The following is a description of a gene set: from publication Hu T, Gibson DP, Carr GJ, Torontali SM, Tiesman JP, Chaney JG, Aardema MJ (PMID 15120960) studied in species Mus musculus Genes most consistently regulated at 4 h by all six genotoxins tested: cisplatin, methyl methanesulfonate, mitomycin C, taxol, hydroxyurea and etoposide. Human Gene Set: HU_GENOTOXIC_DAMAGE_4HR During the safety evaluation process of new drugs and chemicals, a battery of genotoxicity tests is conducted starting with in vitro genotoxicity assays. Obtaining positive results in in vitro genotoxicity tests is not uncommon. Follow-up studies to determine the biological relevance of positive genotoxicity results are costly, time consuming, and utilize animals. More efficient methods, especially for identifying a putative mode of action like an indirect mechanism of genotoxicity (where DNA molecules are not the initial primary targets), would greatly improve the risk assessment for genotoxins. To this end, we are participating in an International Life Sciences Institute (ILSI) project involving studies of gene expression changes caused by model genotoxins. The purpose of the work is to evaluate gene expression tools in general, and specifically for discriminating genotoxins that are direct-acting from indirect-acting. Our lab has evaluated gene expression changes as well as micronuclei (MN) in L5178Y TK(+/-) mouse lymphoma cells treated with six compounds. Direct-acting genotoxins (where DNA is the initial primary target) that were evaluated included the DNA crosslinking agents, mitomycin C (MMC) and cisplatin (CIS), and an alkylating agent, methyl methanesulfonate (MMS). Indirect-acting genotoxins included hydroxyurea (HU), a ribonucleotide reductase inhibitor, taxol (TXL), a microtubule inhibitor, and etoposide (ETOP), a DNA topoisomerase II inhibitor. Microarray gene expression analysis was conducted using Affymetrix mouse oligonucleotide arrays on RNA samples derived from cells which were harvested immediately after the 4 h chemical treatment, and 20 h after the 4 h chemical treatment. The evaluation of these experimental results yields evidence of differentially regulated genes at both 4 and 24 h time points that appear to have discriminating power for direct versus indirect genotoxins, and therefore may serve as a fingerprint for classifying chemicals when their mechanism of action is unknown., and this is the list of marker genes: IFNAR2, MAPRE1, COMMD7, NCDN, BUB1, SMG5, TRAFD1, H3C14, CDC20, TIMP2, TNNC1, CUL1 (NCBI Gene Id 8454), H2AC4, PTTG1, ANLN, ALAS1, H2AX, CKS2, ZSCAN21, CDT1, NEK2 (NCBI Gene Id 4751), CDC25C, SYNCRIP, FAM76B, MTHFD2, ORC5, HLA-B, JUND, AURKA, KPNA2, KIF22, ECT2, PRC1, TCF19, ITGB7, UCK1, HMGN1